Given this list of marker genes SPACA9, LIMCH1, MIPOL1, CPEB4, ERC1, ZFYVE28, NEDD4, PHAX, PAK2, CYRIB, PSMD2, SGPP1, CACNA2D3, MYOZ3, GTF2H5, MDC1, ABCD3, CBX5, DEFB118, SLITRK6, RAB11FIP1, WNT10B, FBXL14, RAB3C, SYNM, MCPH1, MRPL22, CALU, ZSCAN25, DLGAP1, CLXN, NOLC1, RIF1, IRAK1BP1, ARL15, LRRC2, MYLIP, MFAP3, MSI1, CALCR, DIO2, ALG6, KPNA1, NSD3, CNOT2, TRAK2, TTC17, TAF2, CBLB, MAPRE1, GALK2, BOD1L1 (biorientation of chromosomes in cell division 1 like 1), ZNF432, SCAI, SREK1IP1, UGCG, GABRB2, FCAR, PPP1R12A, ZDHHC11 (zinc finger DHHC-type containing 11), FAM204A, BACH1, DNAJC27, CDYL2, WFDC11, LYST, LGALS8, SYT15, ITGAV, SLC4A5, ACVR1C, PTPRG, SNRPB2, CPEB3, ARPC5, NAA25, UBD, MATN3, LPAR4, LHFPL3, CNTNAP5, TGIF1, SOX11, PBX3, GLIPR2 (GLI pathogenesis related 2), TULP4, SNTG1, EML4, PXN, ZMYM4, FBXO42, ATP11AUN, CD151, PGAP1, HOXA5, SCLT1, TEDDM1, ZCWPW2, TINAG, TAC1, here is a description of the gene set: from publication Chen Y, Wang X (PMID 31504780) Genes predicted to be targets of miRBase v22 microRNA hsa-miR-4797-3p in miRDB v6.0 with MirTarget v4 prediction scores > 80 (high confidence targets). Human Gene Set: MIR4797_3P species: Homo sapiens